Given this list of marker genes SLC15A3, MFSD1, SLC15A1, SLC15A2, SLC15A4, here is a description of the gene set: Enables the transfer of a dipeptide from one side of a membrane to the other. A dipeptide is a combination of two amino acids linked together by a peptide (-CO-NH-) bond. studied in species Homo sapiens Human Gene Set: GOMF_DIPEPTIDE_TRANSMEMBRANE_TRANSPORTER_ACTIVITY